The following is a description of a gene set: Reactome Pathway: RET signaling The RET proto-oncogene encodes a receptor tyrosine kinase expressed primarily in urogenital precursor cells, spermatogonocytes, dopaminergic neurons, motor neurons and neural crest progenitors and derived cells.. It is essential for kidney genesis, spermatogonial self-renewal and survivial, specification, migration, axonal growth and axon guidance of developing enteric neurons, motor neurons, parasympathetic neurons and somatosensory neurons. RET was identified as the causative gene for human papillary thyroid carcinoma, multiple endocrine neoplasia (MEN) type 2A, type 2B, and Hirschsprung's disease. <br><br>RET contains a cadherin-related motif and a cysteine-rich domain in the extracellular domain. It is the receptor for members of the glial cell-derived neurotrophic factor (GDNF) family of ligands, GDNF, neurturin (NRTN), artemin (ARTN), and persephin (PSPN), which form a family of neurotrophic factors. To stimulate RET, these ligands need a glycosylphosphatidylinositol (GPI)-anchored co-receptor, collectively termed GDNF family receptor-alpha (GFRA). The four members of this family have different, overlapping ligand preferences. GFRA1, GFRA2, GFRA3, and GFRA4 preferentially bind GDNF, NRTN, ARTN and PSPN, respectively. The GFRA co-receptor can come from the same cell as RET, or from a different cell. When the co-receptor is produced by the same cell as RET, it is termed cis signaling. When the co-receptor is produced by another cell, it is termed trans signaling. Cis and trans activation has been proposed to diversify RET signaling, either by recruiting different downstream effectors or by changing the kinetics or efficacy of kinase activation. Whether cis and trans signaling has significant differences in vivo is unresolved. Different GDNF family members could activate similar downstream signaling pathways since all GFRAs bind to and activate the same tyrosine kinase and induce coordinated phosphorylation of the same four RET tyrosines (Tyr905, Tyr1015, Tyr1062, and Tyr1096) with similar kinetics. However the exact RET signaling pathways in different types of cells and neurons remain to be determined. studied in species Homo sapiens part of: Axon guidance, and this is the list of marker genes: DOK2, PSPN, RET, SHC1, SHANK3, IRS2, FRS2, DOK5, GFRA1, PDLIM7, SHC3, PIK3R2, PIK3CD, PTPN11, PIK3R1, GAB1, PRKACA, DOK4, SRC, PIK3R3, PIK3CA, DOK1, GRB7, NRTN, PRKACG, GFRA3, ARTN, GRB10 (NCBI Gene Id 9769), GFRA2, PLCG1, GFRA4, SOS1, GRB2, PRKACB (protein kinase cAMP-activated catalytic subunit beta), PIK3CB, MAPK7, PRKCA, GAB2, RAP1GAP, GDNF, DOK6